The following is a description of a gene set: Formation of the open complex exposes the template strand to the catalytic center of the RNA polymerase II enzyme. This facilitates formation of the first phosphodiester bond, which marks transcription initiation. As a result of this, the TFIIB basal transcription factor dissociates from the initiation complex.<p>The open transcription initiation complex is unstable and can revert to the closed state. Initiation at this stage requires continued (d)ATP-hydrolysis by TFIIH. Dinucleotide transcripts are not stably associated with the transcription complex. Upon dissociation they form abortive products. The transcription complex is also sensitive to inhibition by small oligo-nucleotides. <p>Dinucleotides complementary to position -1 and +1 in the template can also direct first phosphodiester bond formation. This reaction is independent on the basal transcription factors TFIIE and TFIIH and does not involve open complex formation. This reaction is sensitive to inhibition by single-stranded oligonucleotides. studied in species Homo sapiens Reactome Pathway: HIV Transcription Initiation part of: Transcription of the HIV genome, and this is the list of marker genes: POLR2H, ERCC3, TAF1L, TAF11, POLR2K, GTF2A2, TAF12, MNAT1, CCNH, TBP, POLR2D, GTF2E1, GTF2H5, POLR2E, POLR2F, GTF2H1, TAF7, TAF4B, POLR2G, POLR2I, TAF1, TAF15, GTF2F2, TAF2, GTF2H4, POLR2A, TAF5, GTF2F1, ERCC2, TAF3 (TATA-box binding protein associated factor 3), GTF2H3, POLR2L, GTF2A1, TAF6, TAF9, GTF2H2, POLR2J, TAF10, GTF2E2, TAF8, TAF9B, GTF2B, TAF7L, CDK7, POLR2C, POLR2B, TAF13, TAF4